Given this list of marker genes Lacc1 (laccase domain containing 1), Cuta, Loxl1, Sco2, Sncb, Loxl4 (NCBI Gene Id 67573), Gpc1, Sncg, Ccs, Aoc2, Rnpep, F8, Ang6, Mt1, Cutal, Moxd2, Aoc1l1, mt-Co2, Il1a, Atp7a, Loxl3, Adnp, P2rx2, Cutc, Ang2, Cox11, Hamp, Sod1, Apoa4, Pam, Tyr, Snca, Prnp, Atox1, Prnd, Dbh, Sumf1, Loxl2, Cox17, Sod3, Ahcy, Trp53, Atp7b, Or5ar1, Lox, Aoc1, Ang4, S100a13, Mt3, Aoc3, Ang5, Hephl1, Heph, Slc11a2, Muc2, Coa6, Park7, P2rx7, Prn, F5, P2rx4, Ang, Slc31a1, Aoc1l2, S100a5, Or4e2, Cp, Moxd1, Aoc1l3, Commd1, here is a description of the gene set: Mouse Gene Set: GOMF_COPPER_ION_BINDING Binding to a copper (Cu) ion. studied in species Mus musculus